The following is a description of a gene set: species: Homo sapiens Human Gene Set: MIR489_3P from publication Chen Y, Wang X (PMID 31504780) Genes predicted to be targets of miRBase v22 microRNA hsa-miR-489-3p in miRDB v6.0 with MirTarget v4 prediction scores > 80 (high confidence targets)., and this is the list of marker genes: SLIT2, BEND4, EFCAB11, RELCH, IQSEC3, LONRF2, TENT2, RICTOR, SLC25A21, RASGEF1B, NF2, EMC1, RPP30, LVRN, MAF (NCBI Gene Id 4094), PPARGC1B, TSC1, TENT4B, SRSF1, B4GALT3, ANKRD49 (ankyrin repeat domain 49), SLC2A13, CNTLN, TCEAL6, GLIPR2, GTF3C3 (general transcription factor IIIC subunit 3), ZFP28, SLC7A11, PKP1, PLPP6, TLL1, RIPK4, KLHL13, MEGF10 (NCBI Gene Id 84466), SUZ12, HSF5, PNISR, ACKR4, KCNQ5, JAG1, DCC, RNF111, GPC6, CCAR1, NRIP1, ZNF624, ADAM23, RTN4IP1, EMX2, AIG1, RGS18, ITGB1BP1, ETNK1, DCAF13, SHISA7, ATP1B3, UBE4A, ZNF790, PARM1, NR4A3, DNAJC13, RECK, MAP3K7, PAX3, AMIGO2, PRXL2A, TRAM1, IPO5, IL13, MNS1, SRSF7, IMPA1, SCIN, GABRA4, CREB5, UPF3B, TNFSF4 (TNF superfamily member 4)